The following is a description of a gene set: from publication Chen Y, Wang X (PMID 31504780) Human Gene Set: MIR6804_5P Genes predicted to be targets of miRBase v22 microRNA hsa-miR-6804-5p in miRDB v6.0 with MirTarget v4 prediction scores > 80 (high confidence targets). species: Homo sapiens, and this is the list of marker genes: RNF126, EXOG, NTRK1 (neurotrophic receptor tyrosine kinase 1), BLOC1S6, DLK1, HSPA12A, ETV6, FAM222B, AGAP1, CACNB1, TVP23C, ESYT3, PRR9, MON1B, XCL2, PPP1R11, SMIM7, ARL3, EYA2 (EYA transcriptional coactivator and phosphatase 2), SRRM4, LINC00390, MYD88, RAB41, PPP1R12B, DISC1, NFAM1, HSPA4, CELF3, UNC5B, TMEM121B, JMJD8, E2F4, MASP1, PDGFRB, TAL1, TBL1X, NEMP1, SH2D4B, TM2D3, IQSEC2, AP4B1, ZNF641, COPS6, KCNA6, ARHGAP33, SEMA6D, BTN3A1, AKT3, SLC39A2, SLC29A4, AGXT2, UBE4A (NCBI Gene Id 9354), HPN, CEACAM1, CXXC5, FCER2, USB1, TCHHL1, IRF6, NCR3LG1 (NCBI Gene Id 374383), MEOX1, DGKA, SPMAP2, TP53INP2, MORC4, PRR3, CENPN, TBC1D16, ACTR1A, GP6, KRT14, TUBB4A, PPP4R3B, TENT4B, ADGRA1